Given this list of marker genes LAMA3, ACTA1 (actin alpha 1, skeletal muscle), SGCZ, ACTG2, LAMB1, LAMB2, DRP2, AGRN (agrin), SGCB, LAMA2, DMD, LAMA1, ACTA2, SNTB1, LAMB3, DTNB, ACTG1, DTNA, LAMA4, HSPG2, SGCE, SGCA, ACTB, ACTC1, SSPN, SGCD, LAMA5, LAMC3, DAG1, LAMC2, UTRN (utrophin), SNTG2, SNTB2, SGCG, LAMC1, SNTA1, here is a description of the gene set: Human Gene Set: REACTOME_FORMATION_OF_THE_DYSTROPHIN_GLYCOPROTEIN_COMPLEX_DGC studied in species Homo sapiens Formation of the dystrophin-glycoprotein complex (DGC)